The following is a description of a gene set: species: Homo sapiens Human Gene Set: MIR6500_3P Genes predicted to be targets of miRBase v22 microRNA hsa-miR-6500-3p in miRDB v6.0 with MirTarget v4 prediction scores > 80 (high confidence targets). from publication Chen Y, Wang X (PMID 31504780), and this is the list of marker genes: PHTF2, MPZ, TMEM108, FABP7, C15orf40, PDZD7 (NCBI Gene Id 79955), IRF4, ZNF468, ZNF117, ANK2, ABHD2, NECAB1, TDRD3, ZZZ3, AMMECR1, RHOH, PANK1, EZR, RAB39B, ANKRD33B, ZFAND5, FNBP4, SRPK2, RNF152, ADNP, IFT52, KCTD9, ZNF268, TMEM47, DCAF8L1, USP46, NEXMIF, SLFN14, CDKN2AIP, BRCA2 (NCBI Gene Id 82716), TAFA2, LRP6, MACF1, PPP6R3, HESX1, STT3B, AP4E1, CDK17, FMNL2, KLHL28, MTRF1L, ABRA, EPHA3, RARRES1, ST18, ZNF684, QRICH1, NWD2, DEK (NCBI Gene Id 7913), UTP25, NIPBL, MKI67, RORA (NCBI Gene Id 6095), FNDC3A, NR4A3, SETD2, GPAM, PNPLA8, PITPNA, WIPF1, GABRG3, RBM46, VAMP4, H1-0, RIC1, EMC10, AKAP11, TAPT1 (transmembrane anterior posterior transformation 1), RGS3, MGAM, CEP83, ZNF28, ZNF730, HIPK1, LIN28B, MIA3